The following is a description of a gene set: Genes down-regulated in CD4 T cells: untreated (0h) versus activated by anti-CD3 and anti-CD28 and then stimulated by IL-12 (2h). Th1 and Th2 cells arise from a common precursor cell in response to triggering through the TCR and cytokine receptors for IL-12 or IL-4. This leads to activation of complex signaling pathways, which are not known in detail. Disturbances in the balance between type 1 and type 2 responses can lead to certain immune-mediated diseases. Thus, it is important to understand how Th1 and Th2 cells are generated. To clarify the mechanisms as to how IL-12 and IL-4 induce Th1 and Th2 differentiation and how TGF-beta can inhibit this process, we have used oligonucleotide arrays to examine the early polarization of Th1 and Th2 cells in the presence and absence of TGF-beta after 0, 2, 6 and 48 hours of polarization. studied in species Homo sapiens Human Gene Set: GSE2770_UNTREATED_VS_IL12_TREATED_ACT_CD4_TCELL_2H_DN from publication Lund R, Aittokallio T, Nevalainen O, Lahesmaa R (PMID 14607935), and this is the list of marker genes: TUBA3C, MRPS35, LRP8, SFR1, HES6, ASAH1, HSPA8, ABCD4, TUBB4B, PSMC3, YWHAH, SCARB1, LRRC45, BCL9L, SPNS1, TUBG1, DPH2, PSMA1, PRKAR2A, TMEM184B, CAMKK1 (NCBI Gene Id 84254), FHOD1, FBXO9, SBK1, INCENP, MTX2, ENO2, TRIM32, CCDC117, MMD, KCNN4, GPR180, C11orf24, HNRNPLL, ACO1 (aconitase 1), FTX, CEP19, MSL3, REEP3, EEIG1, PRPS2, ZFPM1 (NCBI Gene Id 161884), GPR68, C3orf80, FIG4, CETN2, OLA1 (NCBI Gene Id 89690), TNK2, ECI2, GIPC1, RPA1, FADS6, ITGA3, HAUS7, HPCAL1 (hippocalcin like 1), CCND3, GTPBP3, FCSK, RPP30, AIRIM, SOAT1, DYRK3, PEX26, TFG, H6PD, DNAJA1, SQLE, LIPT1, CSK, NLRX1, C12orf43, MBLAC1, GDPGP1, C2orf69, TRIM8, RPN1, BPNT1, MKNK2, DIPK2A, RALB (NCBI Gene Id 5899), XYLT2, SH3GLB2, DENND11, MTIF2, GPD1L, DENND4C, DVL2, CD320, TALDO1, CCDC86, LPCAT1, KPNA2, RETREG2, ATPAF1, SCP2, GRSF1, SH3BP5L, MDH2, AKR1B1, MAP2K1, EFHD2, GLB1, CHST2, UBQLN2, SAC3D1, RHOF, TENT5C, CBX6, BAG3, EXTL3, EFCAB14, PHACTR4, GRHL1, TMEM109, SLC19A2, QNG1, TSPAN3, SEPHS2, FLVCR1, ATP23, GPI, MPV17L2 (MPV17 mitochondrial inner membrane protein like 2), ZNHIT2, DEDD2, HSPA1B, SKP1, RAB23, DFFB, AARSD1, SC5D, CTR9, STYX, ZNF32, CCDC116, MPI, APEX2, TRIP10, SLC35C1, VAT1, PRDX2, EID1, AKNA, RAD9A, ALS2CL, TUBA1A, NFXL1, DNAJB1, RNF11, L2HGDH, GYG1, SGSM3, CPM, TSC22D4, HSPH1, PDIA3, NANP, LDLR, CARNMT1, WFS1, PMM1, CHML, PLOD3, NIN, PPARGC1B, SGSM2, SIPA1, CRYBG2, ZNF708, SWT1, PDPR, AMER1, EI24, TYMS, SLC39A10, NHERF1, JPT1, C11orf68, GTF2H2, SPTSSA, ABHD17A, LAMP1, WDR53, KHDRBS1 (KH RNA binding domain containing, signal transduction associated 1), TUBB, TRIP6, ZBTB14, MICAL1, MBNL3, USP21, GNA11, SETD7 (NCBI Gene Id 80854), RXYLT1, TMBIM6, RREB1, HOPX, VDAC1, CCNG1, HYCC2, TEDC2, RECK